Given this list of marker genes C11orf24, PRDM1, ELL2, AMPD1, CANX, UAP1, SLAMF7, MYC, ISG20 (NCBI Gene Id 3669), FBXO16, TUFT1, STAG2, GFPT1, PIM2, CDK6, SUB1, SCD, P4HA1, ITGB7, CASP3, CCNC, PHKA1, DENND2C (NCBI Gene Id 163259), SLC37A4, PAM, E2F5, IRF4, NFIL3 (NCBI Gene Id 4783), DUSP5, TNFAIP3, CFLAR, CDKN1B, TNFRSF17, B4GAT1, MAN2A1, DDR2, here is a description of the gene set: The transcription factor IRF4 (interferon regulatory factor 4) is required during an immune response for lymphocyte activation and the generation of immunoglobulin-secreting plasma cells. Multiple myeloma, a malignancy of plasma cells, has a complex molecular aetiology with several subgroups defined by gene expression profiling and recurrent chromosomal translocations. Moreover, the malignant clone can sustain multiple oncogenic lesions, accumulating genetic damage as the disease progresses. Current therapies for myeloma can extend survival but are not curative. Hence, new therapeutic strategies are needed that target molecular pathways shared by all subtypes of myeloma. Here we show, using a loss-of-function, RNA-interference-based genetic screen, that IRF4 inhibition is toxic to myeloma cell lines, regardless of transforming oncogenic mechanism. Gene expression profiling and genome-wide chromatin immunoprecipitation analysis uncovered an extensive network of IRF4 target genes and identified MYC as a direct target of IRF4 in activated B cells and myeloma. Unexpectedly, IRF4 was itself a direct target of MYC transactivation, generating an autoregulatory circuit in myeloma cells. Although IRF4 is not genetically altered in most myelomas, they are nonetheless addicted to an aberrant IRF4 regulatory network that fuses the gene expression programmes of normal plasma cells and activated B cells. Human Gene Set: SHAFFER_IRF4_MULTIPLE_MYELOMA_PROGRAM from publication Shaffer AL, Emre NC, Lamy L, Ngo VN, Wright G, Xiao W, Powell J, Dave S, Yu X, Zhao H, Zeng Y, Chen B, Epstein J, Staudt LM (PMID 18568025) Direct targets of IRF4 that constitute a multiple myeloma program. studied in species Homo sapiens